Given this list of marker genes STAMBPL1, CEP162, ADAMTS17 (ADAM metallopeptidase with thrombospondin type 1 motif 17), KDM3A, WNK3, ZNF37A, ANKRD60, FNDC3B, WASHC5, ZBTB1, CYRIB, MED13, PDE7B, INSYN2A, FAM149B1, SEMA4D, CAPN7, PEG10, BCL6 (NCBI Gene Id 604), PABPC4, TAL1, BACE2, ATOSA, NDUFS2, CREB3, TEP1, CDIN1 (CDAN1 interacting nuclease 1), CDC14B, CYREN, SHANK2, KLHL3, NECTIN4 (nectin cell adhesion molecule 4), ASPH, here is a description of the gene set: Human Gene Set: MIR1225_5P species: Homo sapiens from publication Chen Y, Wang X (PMID 31504780) Genes predicted to be targets of miRBase v22 microRNA hsa-miR-1225-5p in miRDB v6.0 with MirTarget v4 prediction scores > 80 (high confidence targets).